The following is a description of a gene set: species: Homo sapiens Human Gene Set: REACTOME_TRANSLATION_OF_SARS_COV_2_STRUCTURAL_PROTEINS Translation of Structural Proteins, and this is the list of marker genes: ZDHHC5, MOGS, SUMO1, CANX, MGAT5, STT3A, UBB, ZDHHC3, OST4, UBC, MGAT4C, OSTC, PARP16, RPS27A, TMEM258, ST3GAL2, ZDHHC8, ZDHHC20, ST6GAL1, SRPK1, CSNK1A1, ST6GALNAC4, GANAB, PRKCSH, GSK3B, MAN2A1, MGAT4A (alpha-1,3-mannosyl-glycoprotein 4-beta-N-acetylglucosaminyltransferase A), ST3GAL3, RPN1, ST3GAL1, MAN1B1, RPN2, UBE2I, DDOST, PARP10, ST3GAL4, UBA52, PARP9, GALNT1, ST6GALNAC3, ZDHHC11, PARP6, SRPK2, MAGT1, PARP14, EDEM2, PARP8, ZDHHC2, TUSC3, GSK3A, MGAT2, MGAT4B, FUT8, PARP4, ST6GALNAC2, STT3B, MGAT1, ZDHHC9, GOLGA7, PRMT1, DAD1